The following is a description of a gene set: Human Gene Set: GOMF_CADHERIN_BINDING_INVOLVED_IN_CELL_CELL_ADHESION species: Homo sapiens Any cadherin binding that occurs as part of the process of cell-cell adhesion., and this is the list of marker genes: ANXA2 (NCBI Gene Id 792), TRIM29, RAB10, BAIAP2L1, EPCAM, KRT18, S100A11, PDLIM5, CNN3, PDLIM1, BAIAP2, PAK4, CDC42EP1, ANXA1, STXBP6, PKP3, PPP1CA, TMOD3